Given this list of marker genes SP7, MAF, SATB2, CBFB, MAPK1, RB1, IHH, GLI2, MAPK3, SMAD4, RUNX2, HEY2, UCMA, ABL1, WWTR1, AR, COL1A1, YES1, YAP1, SMAD6, HDAC6, HES1, HDAC3, ZNF521, GLI3, HEY1, RBM14, BGLAP, SMAD1, HDAC4, SRC, here is a description of the gene set: RUNX2 regulates bone development studied in species Homo sapiens Human Gene Set: REACTOME_RUNX2_REGULATES_BONE_DEVELOPMENT